Given this list of marker genes Cenpc1, Mlh1, Knl1, Zwint, Brca2, here is a description of the gene set: A cell cycle process whereby homlogous chromosomes are positioned in a specific order and orientation at the metaphase plate (spindle equator) by the spindle machinery and centromere/kinetochore arrangement during meiosis I chromosome segregation. This alignment ensures that each daughter cell will receive the correct number of chromosomes during cell division. Mouse Gene Set: GOBP_MEIOTIC_METAPHASE_I_HOMOLOGOUS_CHROMOSOME_ALIGNMENT studied in species Mus musculus